Given this list of marker genes YRDC, DONSON, AP1S2, SLC12A6, NUP133, FGFR2, CHD7, CLCN3, WDR4, L1CAM, ZIC3, WDR73, PLCH1, LAGE3, IFT56, TPRKB, GON7, ROBO1, FANCB, OSGEP, SF3B4, TP53RK, FGFR1, SMARCC1, SEMA3E, NF1, NUP107, POLR1A, here is a description of the gene set: species: Homo sapiens Human Gene Set: HP_AQUEDUCTAL_STENOSIS Aqueductal stenosis Stenosis of the cerebral aqueduct (also known as the mesencephalic duct, aqueductus mesencephali, or aqueduct of Sylvius), which connects the third cerebral ventricle in the diencephalon to the fourth ventricle, which is between the pons and cerebellum.